The following is a description of a gene set: from publication Chen Y, Wang X (PMID 31504780) Genes predicted to be targets of miRBase v22 microRNA mmu_miR_667_5p in miRDB v6.0 with MirTarget v4 prediction scores > 80 (high confidence targets). species: Mus musculus Mouse Gene Set: MIR_667_5P, and this is the list of marker genes: Rab7b, Lhfpl3, Epx, Chrd, Rad51c, Cep350, Stom (NCBI Gene Id 227754), Phf21a (PHD finger protein 21A), Dtx4, Heyl, BC048671, Fam168a, Peg10, Tnpo3, Hdac9, Tas1r3, Fabp3, Zfp746, Prodh2, Tsr2, Glrb, Mtcl2, Stab2, Thbs2, Atpaf1, Ubtd2, Leng8, Smap2, Brpf3, Tcte1, Znhit3 (zinc finger, HIT type 3), Triml1, Atp5f1a, Xpnpep2, Deup1, Fbxo32, Dpysl5, Cr2, Fubp1, Plxdc2, Usp3, Nppa, Dbndd2, Ano3, Plaat3, Mfsd14a, Igf2bp2, Relt (NCBI Gene Id 320100), Mapk4, Comtd1, Serpina5, Prdm2, Dnmt3a, Stk4, Epha8, Nrf1, Nova1, Tbx19, Ube3d, Ascl1, Luzp1, Aars1, Mat2a, Sypl2, Msi2, Spcs1, Fgfr2, Inmt, Ciita, 4930571K23Rik, Foxo3